The following is a description of a gene set: Mouse Gene Set: REACTOME_REGULATION_OF_CHOLESTEROL_BIOSYNTHESIS_BY_SREBP_SREBF species: Mus musculus Regulation of cholesterol biosynthesis by SREBP (SREBF), and this is the list of marker genes: Scap, Srebf1, Mbtps2, Ran, Srebf2, Kpnb1, Mbtps1